The following is a description of a gene set: Human Gene Set: GOBP_CRANIAL_NERVE_FORMATION The process that gives rise to the cranial nerves. This process pertains to the initial formation of a structure from unspecified parts. The cranial nerves are composed of twelve pairs of nerves that emanate from the nervous tissue of the hindbrain. These nerves are sensory, motor, or mixed in nature, and provide the motor and general sensory innervation of the head, neck and viscera. They mediate vision, hearing, olfaction and taste and carry the parasympathetic innervation of the autonomic ganglia that control visceral functions. studied in species Homo sapiens, and this is the list of marker genes: TIFAB, PLXNA1, DCANP1, MAFB, NEUROG1, HOXA1, PAX2, PLXNA3, ATP8B1, TFAP2A, PHOX2A